Given this list of marker genes FCGR3A, PTPN22, JAK2, ELF4, FLT3LG, SLAMF1, IL23R, STAT5B, RPL13A, TYK2, IL15, EMP2, HLA-E, IL18, IL23A, LEP, IL12B, here is a description of the gene set: studied in species Homo sapiens The expansion of a natural killer cell population by cell division. Human Gene Set: GOBP_NATURAL_KILLER_CELL_PROLIFERATION